Given this list of marker genes Bex3, Ngf, Ntf3, Ntf5, Bdnf, here is a description of the gene set: Binding to a nerve growth factor receptor. species: Mus musculus Mouse Gene Set: GOMF_NERVE_GROWTH_FACTOR_RECEPTOR_BINDING